The following is a description of a gene set: Any process that results in a change in state or activity of a cell or an organism (in terms of movement, secretion, enzyme production, gene expression, etc.) as a result of an epinephrine stimulus. Epinephrine is a catecholamine that has the formula C9H13NO3; it is secreted by the adrenal medulla to act as a hormone, and released by certain neurons to act as a neurotransmitter active in the central nervous system. studied in species Mus musculus Mouse Gene Set: GOBP_RESPONSE_TO_EPINEPHRINE, and this is the list of marker genes: Ryr2 (ryanodine receptor 2, cardiac), Penk, Nos1, Akap6, Slc9a1, Abl1, Adipoq, Atp2b4, Sirt2 (NCBI Gene Id 80489), Pde4d, Kcnq1, Star